The following is a description of a gene set: The lipid bilayer surrounding a clathrin-coated vesicle. species: Mus musculus Mouse Gene Set: GOCC_CLATHRIN_COATED_VESICLE_MEMBRANE, and this is the list of marker genes: Cemip, Atp6v0d1, Dab2, Cltc, Syn1, Nrgn, Sgip1, Ap2s1, Atp6v1b2, Syt11, Slc17a8, Vamp3, Atp6v1d, Cltb, Ap1g1, Synrg, Atp6ap1, Eps15, Epn2, Ap3b2, Ap4b1, Tbc1d5, Ap1s3, Epn1, Atp6v1h, Atp6ap2, Hip1r, Atp6v1g2, Btbd8, Clta, Vamp2, Ap1s1, Dbnl, Rab3a, Hip1, Atp6v1c1, Atp6v1f, Otof, Clba1, Clint1, Ap1g2, Ston1, Epn3, Gad2, Ap1b1, Enthd1, Dennd1a, Ap1m2, Syp, Atp6v0e2, Tyrp1, Snap91, Ston2, Necap2, Arc, Atp6v0a1, Rnasek, Ap2b1, Ap2m1, Atp6v0b, Ap1s2, Ap3b1, Gad1, Adcy8, Atp6v1a, Furin, Dnajc5, Ap2a1, Slc18a3, Necap1, Atp6v1e1, Ap1m1, Ap2a2, Reep6, Aftph, Rassf9 (Ras association (RalGDS/AF-6) domain family (N-terminal) member 9), Atp6v0c